Given this list of marker genes Aldob, Pfkl, Pfkm, Slc2a5, Aldoa, Clec4g, here is a description of the gene set: species: Mus musculus Binding to the D- or L-enantiomer of fructose, the ketohexose arabino-hex-2-ulose. Mouse Gene Set: GOMF_FRUCTOSE_BINDING